The following is a description of a gene set: Human Gene Set: GOMF_LIPID_PHOSPHATASE_ACTIVITY species: Homo sapiens Catalysis of the reaction: a phospholipid + H2O = a lipid + phosphate., and this is the list of marker genes: PLPP3, LPIN1, PLPP5, PLPP1, LPIN3, INPP5K, PLPP4, PLPPR1, PLPP6, PLPPR2, PLPPR3, SGPP2, LPIN2 (lipin 2), PLPP2, PLPP7, EPHX2, SGPP1, PLPPR4, PLPPR5